Given this list of marker genes Park7, Nubp1, Zng1, Nubpl, Nubp2, Pcbp1, Pcbp2, Ccs, Dph3, Atp7a, Atox1 (NCBI Gene Id 193132), Cox17, Fxn, Trf, Sco2, here is a description of the gene set: Mouse Gene Set: GOMF_METALLOCHAPERONE_ACTIVITY Binding to and delivering metal ions to a target protein. species: Mus musculus